The following is a description of a gene set: species: Homo sapiens Human Gene Set: GOBP_CORTICAL_CYTOSKELETON_ORGANIZATION A process that is carried out at the cellular level which results in the assembly, arrangement of constituent parts, or disassembly of cytoskeletal structures in the cell cortex, i.e. just beneath the plasma membrane., and this is the list of marker genes: LLGL2, FMNL1, KCNC3, ARF6, FMNL3, RHOBTB2, AKAP11, PAFAH1B1, RAC2, LLGL1, ROCK2, FHOD3, ROCK1, EPB41L3, FHOD1, EZR, RACGAP1, CAVIN3, RAB13, KANK1, VIL1, TLN1, NCKAP1, PPP2R3C (NCBI Gene Id 55012), TRPV4, EPB41L2, PLEK, EPB41, IQGAP2, KIF21A, VPS4A, STRIP1, DLG1, PLS1, RHOQ, PPFIBP1, FMNL2, RHOBTB1, CALR, PLEC, IQGAP1, PPFIA1, NLGN1, WDR1, EHD2, PTK2B, RAC3, RTKN, PDCD6IP (programmed cell death 6 interacting protein), ANLN, NCKAP1L, ECT2, EPB41L1, RHOG, LCP1, IQGAP3, RAC1